Given this list of marker genes FLI1, CCNDBP1, CSTPP1, C1orf198, SERPINB2, FCGR1A, SLC3A1 (solute carrier family 3 member 1), ATP5F1B (ATP synthase F1 subunit beta), DHFR, EGFR, PPIH, CYB5B, SET, IFITM2, IARS2, IFITM3, NDUFC1, ARFGEF2, MBOAT7, H4C3, UBALD2, NDUFA2, EIF3F, ARMC9, MDH1, MON1B, ISCU, ASNS, COL3A1, BANF1, PTCD3, SIGMAR1, PGK1, ATP5PO, PPP1CC, H2AZ1, ATP5MF, TMSB4X, MTX2, RSU1, PSAT1, UQCR10, PTMA, SLC4A5 (solute carrier family 4 member 5), EPC1, FMNL1, LDHA, MDH2, UGGT2 (NCBI Gene Id 80239), HEATR4, TRIM28, here is a description of the gene set: Human Gene Set: APPIERTO_RESPONSE_TO_FENRETINIDE_DN studied in species Homo sapiens Genes down-regulated in A2780 cells (ovarian carcinoma) exposed to fenretinide. Fenretinide (4-HPR) is a synthetic retinoid with antitumor activity, which induces apoptosis in cancer cell lines of different histotypes. To identify genes contributing to its apoptotic activity in ovarian cancer cells, we monitored, by cDNA arrays, gene expression changes after 4-HPR exposure in A2780, a human ovarian carcinoma cell line sensitive to the retinoid. Among the differentially expressed transcripts, PLAcental Bone morphogenetic protein (PLAB), a proapoptotic gene, was the most highly induced. In a panel of ovarian carcinoma cell lines with different 4-HPR sensitivities, PLAB upregulation was associated with cellular response to 4-HPR, its overexpression increased basal apoptosis and its silencing by small interfering RNA decreased the ability of 4-HPR to induce apoptosis. PLAB induction by 4-HPR was p53- and EGR-1 independent and was regulated, at least in part, by increased stability of PLAB mRNA. PLAB up-modulation by 4-HPR also occurred in vivo: in ascitic cells collected from patients with ovarian cancer before and after 4-HPR treatment, PLAB was upmodulated in 2/4 patients. Our results in certain ovarian cancer cell lines indicate a role for PLAB as a mediator of 4-HPR-induced apoptosis. The correlation of increased PLAB in vivo with antitumor activity remains to be established. from publication Appierto V, Villani MG, Cavadini E, Gariboldi M, De Cecco L, Pierotti MA, Lambert JR, Reid J, Tiberio P, Colombo N, Formelli F (PMID 17213814)